Given this list of marker genes Rsph3a, Gigyf1 (GRB10 interacting GYF protein 1), S100a8, Tuba1b, Cd44, Car4, Wwp1, Smo, Tsku, Enah, Dph7, Dele1, Ppp1r37, Zfp654, Lgals4, Pvt1, Odf2, Rtn4, Ppp1cc, Map7d1, Atxn2l, Emb, Arhgef1, Ces2c, Calml4, Snrpc, Furin, Cep170b (centrosomal protein 170B), Antxr1, Shisa5, Ctbp2, Vps35, Dvl3, Mzt1, Cited2, Mtln, Arpc5, Sirt1, Arhgap35, Rufy1, Nup153, Sephs1, Alas2, Amfr, Selplg, Tshz1, Mapk3, Dgka, Rbp4 (NCBI Gene Id 19662), Prap1, Dazap1, Atxn1l, Ccdc43, Tstd1, Zfhx4, Ttpal, Chd1 (NCBI Gene Id 75119), Naa15, Tmsb10, A130010J15Rik, Akr1c12, Abhd17a, Pmepa1, Rab5c, Aldh1a1, E130317F20Rik, Arnt, Setd7, Cnot3, Smim24 (NCBI Gene Id 72273), Txlng, Rbpj, Tlk1, Coq8b, Cbx7, Phlpp1, Rnf10, Ndufs5-ps, Styx (serine/threonine/tyrosine interaction protein), Hba-a1, Sh2b1, Prickle3, Slc25a38, Adnp, Wbp11 (WW domain binding protein 11), Azin1, Tspan1, Cyrib, Rap2b, Pura, Gnb2, Jak3 (Janus kinase 3), Rps6kb1, Ivl, Sec61g, Ftl1, Ric8b, Sirt6 (sirtuin 6), Hmga1, Stx16, Ddx21, Gpsm3, Bltp1, Grb2, Ces2e, Mbd3, Ckb, Swt1 (SWT1 RNA endoribonuclease homolog (S. cerevisiae)), Oaz1, Emcn, Rev1, Tspan7, Myef2, Rad23b, Washc5, Tagap (T cell activation Rho GTPase activating protein), Ethe1, Rwdd1, Pdk1 (pyruvate dehydrogenase kinase, isoenzyme 1), Arid1b, Aco2, Sult1b1 (NCBI Gene Id 56362), Slc51a, Bsdc1, Trim28 (tripartite motif-containing 28), Fam120b, Agpat1, Trf, Brox, Smox, Gpt, Socs5, Angel2, Rbsn, Usp14, Fam162a, Gstm5, Sertad2, Ppwd1, Usp40, Pdlim1, Hdhd3, Fbxo10, Bhlhe40, Pi4kb, Ttll12, Rufy2, Cd248, Cplx2, Cdkn2b, Ier3, Sdcbp2, Bloc1s6, Golim4, Cep350, Syde1, Hilpda, Tcim, Brap, Zfp445, Laptm5, Mmd, Kidins220, Rac2, Serinc5, Scaf1, Otud5, Macrod1, Dld, Calcoco1, Ces2a (carboxylesterase 2A), Mpped2, Ppp3ca, Klf3, Pcyox1l, Ube2m, Ddb2, Fam83e, Mettl1, Ddx10, Clic4, Ampd3, Kpnb1, Spag9, Grhl2, Csde1, Actr3, Esyt1, Mrps15, Mrtfa, Aco1, Mapk8ip3, Mfn2, Gga1, Hnrnpul1, Ap2s1, Ybx1, Anapc4, Reep3, Tmem181c-ps, Eno1b, Sltm, Mbp, Lipe, Prune2, Ywhab, Myo1a, Lmo4, Mtmr6, Gtf3c2, Pcbp2, Map2k7, Kat7, Rictor, Ncoa1, Tmcc2, Cemip2, Cdhr5, Ldhb, Bbs2, Bfar, Yipf6, Rxrb, Prss22, Rab34, Col14a1, Srpx, Smndc1, Maml2, Hspa1b, Ptk2, Marcksl1, AA467197, Eed, Pex1, Cat, Etv6, Muc13, Abhd6, Mansc1, Mgst3, Adgra3, Ercc2, Cdc37l1, Slc25a23, Tial1, Stk24, Akr1b8, Ceacam1, Cwc15, Lcp1, Fam83h, Klf16, Dhx37, Acly, Dlat, Tmem231, Ifnar1, Rbm45, Ube2z, Cdk8, Btg3, S100a9, Zfp182, Tcf7l2, Card6, Dusp5, Tmprss4, Sectm1a, Dhx15 (NCBI Gene Id 13204), Pus1, Klf2, Chd4, Scd1, Bcl7c, Calm1, C920021L13Rik, Hsd17b2, Klhl18, Papss2 (NCBI Gene Id 74170), Phgr1, Krt15, Jund, Myo10, Ap2b1, Lrrc39, Rnaset2b, Isy1, Stat2, Ttc39b, Pabpc1, Car3, Rassf3, Lamtor4, Serpinb1a, Irf2bpl, Pck1, Lrrc45, Ropn1l (ropporin 1-like), Tmem87a, Ankrd13c, Ptms, Acaa1b, Itprid2 (NCBI Gene Id 70599), Plagl2, Clint1, Eno1, 4921511C10Rik (NCBI Gene Id 70924), Smad4, Ptpn2, Smap1, Mgmt, Rgl3, Rars1, Fth1, 2310022B05Rik, Trp53bp1, Wwc1, Leng1, Nub1, Bmal1, Alad, Apol11b, Inhbb, Foxj1, Mdm2, Bcl2l11, Whamm, Nutf2, Tbl1x, Abi2, Nr2c2ap, Taf1, Samhd1, Lrrc58, Espn, Mdfi, Niban2, Ppm1a, Abcb1a, Cavin1, Zdhhc21, Mtmr10 (myotubularin related protein 10), Mknk2, Paxip1, Snd1, Man2b1, Rel, Gypa, Pgp, Hpf1, Borcs6, Il6st, Ptbp3, Scand1, Caprin1, Bmt2, Cdh17, Zcchc8, Iscu, Cobll1, Ctss, Zbed6, Ankle2, Iqsec1, Capn7, Fabp2, Epb41l4b, Atn1, Plekhf2, Ankrd12, Anp32e, Ndufs5, Mapkapk2, Tmem167b, BC005537, Cdan1, Fbxl5, Zc3h13, Slc39a4, Rtn4ip1 (NCBI Gene Id 52025), Gtf2h3, Ttc6, Snrnp70, Trim14, Rnf19a, Mal, Tdrd3, Polk, Phf11d, Caap1, Smap2, 2700097O09Rik, Prr13, Gm6654, Itgav, Ube2s, Csf2ra, Gm12191, Akap8, Inip, Dbi, Atosa, Fam220a (family with sequence similarity 220, member A), Scin (NCBI Gene Id 20259), Tab2, Eif2s3x, Slc44a2, Msrb1, Mcl1, Trim7, Pdlim4, Strn3, Abcc5, Purb (NCBI Gene Id 76437), Tnrc6b, Bcl7b, Sh3glb1, Mep1a, Fubp1, Uimc1, Dcaf6, Akr1b1, Phlda1, Rps15a-ps6, Tob2, Sap130, Gcnt3, Saa1, Sox13, Smim22, Sptbn1, Inpp5f, Guca2a, Cep95, Dmbt1, Mapk12, Tuba1a, Tet2, Nfkb2, Rap1a, Apoe, Dhx40, Tex10, Erdr1, Tns4, Gpr34, Lyz2, Hyou1, Map3k11 (NCBI Gene Id 76541), Vbp1, Hexb, Strn, Dcaf5, Taok2, Synj2bp, Gata3un, Smc4, Krit1, Tnfaip8, Vsir, F930017D23Rik, Opa1, Lypd8, Kdm6b, Parp12, Phf12, Zbtb11, Pde4a, Snx22, Tmem45b, Cdk11b, Gfod1, Cpt1a, Gpr15lg, Lsm14b, Rab27a, Pxn, Tmt1b, Gnas, Aqp8, Rgs3, Ucp2, Nfatc3, Selenop, Vsig2, Ccl2 (NCBI Gene Id 20296), Hnrnpd, Med13l, Tmem238, Cherp, Nfib, Cyp2c55, Bptf, Ptgs1, Fus, Car2, Pglyrp1, Haus2, Cse1l, Morf4l1-ps1, Cfl1, Fmo2, Zfp609, Ppp1cb, Epb41, Rfk, Ccdc61, Ube2r2, Ctc1, Slc24a5, Dync1i2, Dusp6, Tle5, Stmp1, Ccnh, Cycs, Xpa, Prune1, Mical1, Ncbp3, Impact, Arl8a, Sidt2, Ptp4a1, Car1, Slc4a1, 2200002D01Rik, Spindoc, Dpysl2, Adamtsl1, Ms4a8a, Ivd, Ubqln2, Ube2v2, Aph1b, Pum2, Fam117a, Ankrd33b, Ppp1r14d, Gm3336, Snca, Ppp3r1, Camta2, Ppp1r9b, B4galnt2, Fam83b, Dynlt1f, Tmigd1, Cdk2, Plaur (plasminogen activator, urokinase receptor), Cldn23, Nfkbiz, Lrp5, Ckmt1, here is a description of the gene set: Mouse Gene Set: TABULA_MURIS_SENIS_SUBCUTANEOUS_ADIPOSE_TISSUE_EPITHELIAL_CELL_AGEING from publication Tabula Muris Consortium (PMID 32669714) species: Mus musculus